The following is a description of a gene set: studied in species Homo sapiens The autophagic process that proceeds via the formation of an autophagosome. Human Gene Set: GOBP_MACROAUTOPHAGY, and this is the list of marker genes: UBQLN4, WIPI1, STBD1, UCHL1, UBXN2A, CAPN1, VPS13C, CHMP6, PIK3CA, CTTN, PAFAH1B2, ATP6V0B, PIP4K2A, TECPR1, ATG13, RAB2B, RAB33B, ATG16L1, CSNK2A2, PRKN, SESN3, TBC1D14, RB1CC1, SNF8, UFL1, DELE1, SPG11, CLN3, TSPO, RNF41, SNX32, SNX14, MTMR14, TCIRG1 (NCBI Gene Id 8845), C9orf72, RUFY4, IFT88, VPS36, ATP6V1G1, RNF31, VPS16 (NCBI Gene Id 64601), EIF2S1, GAA, VPS37B, ADRB2, YOD1 (NCBI Gene Id 55432), VPS33B, ZDHHC19, CHMP4BP1, HTRA2, NAT8B, CHMP4A, CHMP4C, ATP6V1B1, NBR1, TRAF6, CERS1, KLHL3, DCN, USP30, NIPSNAP3A, HDAC6, HTT, BNIP3, ATG2B, PACS2, POLDIP2, MAPK8, RNF5, ATP6V0D2, ATP6V0E2, EPM2A, AMBRA1, RNF186, ULK2, WDR45B, ATP6V1A, VPS41, FKBP8, SLC25A5, CALCOCO2, ACBD5, RAB39A, EXOC8, TP53INP1, SLC25A4 (solute carrier family 25 member 4), ATP6V1B2, ATP5IF1, LGALS8, RETREG2, HSPB8, EFNB1, HMOX1, NSFL1C, MFSD8, CSNK2A1, TMEM39A, ATG10, HK2, CDK5RAP3, UVRAG, VPS33A, LRBA, WIPI2, VPS13D, TIMM23, SNAPIN, AP4M1, GNAI3, WDFY3, PGAM5, WDR81, VCP, TMEM74, LACRT, LYPLA1, ARHGAP26, CHMP4B, ZNRF1, TBC1D25 (TBC1 domain family member 25), IKBKG, ARL8B, CHMP1B, VTA1, RAB33A, PIKFYVE, CTSD, ATP6V1E2, ATP6V0A2, RAB23, BAG3, CHMP7, UBXN6, CASP3, CALM1, NOD1, ATG14, PJVK, ELP6, VPS4B, ATP6V0D1, ZNRF2, SNX6, RBX1, SNX18 (sorting nexin 18), PLEKHM1, PIM2, MAP1LC3B2, VIPAS39, PLAA, VPS26A, FEZ1, RAB2A, TMEM41B (NCBI Gene Id 440026), VPS28, ATG2A, TSC1, PIK3C2B, CLEC16A, EMC6, AFG2B, UBXN2B, STX17, ATP6V1C1, RAB3GAP2, EIF2AK1, LRSAM1, SNX7, ATM, UFC1, SMCR8, RAB1A, PHF23, PHB2, ULK3, UFM1, MTMR3, ATG5, RETREG3, MTOR, FUNDC1, STAM, IRGM, RAB1B, IL4, RAB3GAP1, OPTN, BNIP3L, RIMOC1, RUBCN, KDR, SNX4, SNX5, ADCY10, NEDD4, LRRK2, AP5Z1, UBQLN1, PEX2, WDR24, ATG9B, HUWE1, SNAP29, CHMP2A, TSC2, TBK1, CHMP5, RAB5A, GABARAPL3, RAB19, DNM1L, UBA5, TBC1D5, ZFYVE26, ABI2, ATG3, AUP1, ATG16L2, NRBP2, MAP1LC3B, ATP6V1C2, SPTLC1, SEC22B, RHEB, FYCO1 (FYVE and coiled-coil domain autophagy adaptor 1), ARFIP2, STING1, GABARAPL2, ATG4D, UBE2A, RUBCNL, ATG4C, RIPK2, SNX30, EPHB2, NOD2, SCOC, MTM1, OGT, MFN2, SIRT1, ULK1, PRKACA, VAMP8, PINK1, FBXL4, MCOLN1, EI24, GPSM1, TIGAR, ATP13A2, CHEK2, CDK5R1, SH3GLB1, SPART, TOM1, VAMP7, LARP1, ATP6V0A1, GBA1, TP53, TRIM13, GAPDH, QSOX1, CAPNS1, ATG4A, RETREG1, CTSK, GABARAPL1, PIP4K2B, SQSTM1, DDRGK1, CDK5, ATG7, BECN2, EXOC1, MAP1LC3C, VPS26B, NPC1, TOMM7, ATP6V1H, SREBF1, LIX1, AKT1, BCL2L13, UBQLN2, TRIM32 (NCBI Gene Id 3971), ATP6V0C, DIAPH3, PSEN1, WAC, FEZ2, RNF213, ATP6V1E1, CDC37, LIX1L, USP36, SESN1, SPATA33, ERN1, MUL1, TSG101, ATG4B, ILRUN, IRGQ, BECN1 (NCBI Gene Id 8678), EHMT2, ATP6V1D, MOAP1, MAP1LC3A, VPS37D (VPS37D subunit of ESCRT-I), RAB43, PRKAA2, VPS39, CHMP3 (charged multivesicular body protein 3), TP53INP2, VMP1, SPTLC2, DNAJC16, SESN2, PARL, ELAPOR1, HDAC10, PDCD6IP, VTI1B, PPTC7, SREBF2, ZFYVE1, ELAVL1, ATG101, EPG5, PEX5, WDR45, LZTS1, NIPSNAP1, TBC1D12, SUPT5H, EXOC7, PIK3C3, RAB1C, NUPR1, VPS35, VPS37A, MVB12A (NCBI Gene Id 93343), SRC (SRC proto-oncogene, non-receptor tyrosine kinase), ATP6V0E1, CHMP2B, GSK3A, STAM2, VDAC1, MAPK3, ATP6V1G2, EXOC4, FBXW7, GABARAP, ATP2A2, FZD5, FBXO7, RAB7A, NIPSNAP2, KAT5 (NCBI Gene Id 10524), TEX264, HGS, LAMP2, IFT20, VTI1A, HIF1A, ATG12, STX12, ARMC3, RALB, STUB1, MAP3K7, ATG9A, CHMP1A, NIPSNAP3B, PIP4K2C (phosphatidylinositol-5-phosphate 4-kinase type 2 gamma), MTMR8, VPS25, SCFD1, VPS37C, VPS4A, PIK3R4, SMURF1